Given this list of marker genes Satb1, Nup35, Cbx8, Pom121, Hdac1, Nup42, Ring1, Pias1, Nup62, H4c17, Nup93, H4c11, H4c2, H4c12, Tpr, Ndc1, Scmh1, Satb2 (NCBI Gene Id 212712), H4c6, H4c3, Pcgf2, Nup37, H4c8, Ube2i, Nup88, Ranbp2, H4c9, Sumo3, Nup50, Nup133, Aaas, H4c4, H4c1, Suz12, Nup214, H4c14, Nup98, Nup153, Nup155, Cbx2, L3mbtl2, Nup160, Nup43, Sumo1, Phc2, Nup58, Nup188, Rae1, Pias2, Bmi1, Nup54, Phc3, Nup205, Phc1, Sec13, Rnf2, Hdac4, Sumo2, H4c16, Cbx4, H4c18, Nup107, Nup85, Nup210 (NCBI Gene Id 54563), Seh1l, here is a description of the gene set: SUMOylation of chromatin organization proteins species: Mus musculus Mouse Gene Set: REACTOME_SUMOYLATION_OF_CHROMATIN_ORGANIZATION_PROTEINS